Given this list of marker genes KRT7, PARVB, PEA15, CST6, SERPINE1, ADAMTS15, here is a description of the gene set: Parvin-beta is a focal adhesion protein downregulated in human breast cancer cells. Loss of Parvin-beta contributes to increased integrin-linked kinase activity, cell-matrix adhesion, and invasion through the extracellular matrix in vitro. The effect of ectopic Parvin-beta expression on the transcriptional profile of MDA-MB-231 breast cancer cells, which normally do not express Parvin-beta, was evaluated. Particular emphasis was placed upon propagating MDA-MB-231 breast cancer cells in three-dimensional culture matrices. Interestingly, Parvin-beta reexpression in MDA-MB-231 cells increased the mRNA expression, serine 82 phosphorylation (mediated by CDK9), and activity of the nuclear hormone receptor peroxisome proliferator-activated receptor gamma (PPARgamma), and there was a concomitant increase in lipogenic gene expression as a downstream effector of PPARgamma. Importantly, Parvin-beta suppressed breast cancer growth in vivo, with associated decreased proliferation. These data suggest that Parvin-beta might influence breast cancer progression. Genes up-regulated in MDA-MB-231 cells (breast cancer) upon overexpression of PARVB under all three culture conditions. from publication Johnstone CN, Mongroo PS, Rich AS, Schupp M, Bowser MJ, Delemos AS, Tobias JW, Liu Y, Hannigan GE, Rustgi AK (PMID 17998334) Human Gene Set: JOHNSTONE_PARVB_TARGETS_1_UP species: Homo sapiens